The following is a description of a gene set: Female hypogonadism Decreased functionality of the female gonads, i.e., of the ovary. Human Gene Set: HP_FEMALE_HYPOGONADISM species: Homo sapiens, and this is the list of marker genes: ATM, AIP, GNRHR, ZMPSTE24, CDH23, PROK2, PRLR, KISS1R, BMP4, DUSP6, FSHB, GNRH1 (gonadotropin releasing hormone 1), CHD7, WDR11, FGFR1, TACR3, PROKR2, FGF8, HS6ST1, MEN1, FGF17, NSMF, NHLH2, TAC3, KISS1, LMNA, AIRE, SPRY4